The following is a description of a gene set: Human Gene Set: REACTOME_METABOLIC_DISORDERS_OF_BIOLOGICAL_OXIDATION_ENZYMES studied in species Homo sapiens Metabolic disorders of biological oxidation enzymes, and this is the list of marker genes: FDX2, CYP21A2, FMO3, CYP27A1 (cytochrome P450 family 27 subfamily A member 1), CYP4F22, CYP24A1, CYP27B1, CYP2R1 (NCBI Gene Id 79445), MAT1A, CYP1B1, FDX1, SLC35D1, GGT1, CYP19A1, MAOA, FDXR, CYP26C1, CYP11B2, CYP26B1, CYP7B1, UGT1A1, UGT1A4, CYP2U1, CYP11B1, GCLC, TBXAS1, GCLM, CYP11A1, TPMT, CYP17A1, GSS (NCBI Gene Id 2937), ACY1, AHCY, OPLAH